The following is a description of a gene set: species: Mus musculus Binding to telethonin, a protein found in the Z disc of striated muscle and which is a substrate of the titin kinase. Mouse Gene Set: GOMF_TELETHONIN_BINDING, and this is the list of marker genes: Kcne1, Myoz3, Myoz1, Myoz2, Ttn, Csrp3, Bmp10